The following is a description of a gene set: studied in species Mus musculus electronically inferred by orthology from the curated human pathway Reactome Pathway: Neurexins and neuroligins part of: Protein-protein interactions at synapses This event has been computationally inferred from an event that has been demonstrated in another species.<p>The inference is based on the homology mapping from PANTHER. Briefly, reactions for which all involved PhysicalEntities (in input, output and catalyst) have a mapped orthologue/paralogue (for complexes at least 75% of components must have a mapping) are inferred to the other species., and this is the list of marker genes: Dlg4, Nlgn3, Dlg3, Nlgn2, Sh3glb2, Shank3, Lrrtm2, Homer1, Dlgap2, Epb41l1, Lrrtm1, Lrrtm4, Lrrtm3, Homer3